Given this list of marker genes Slc39a2, Slc30a1, Slc39a8, Slc39a1, Slc30a8, Slc39a7, Slc39a4, Slc39a3, Slc30a5, Slc39a14, Slc39a6, here is a description of the gene set: Zinc transporters Mouse Gene Set: REACTOME_ZINC_TRANSPORTERS species: Mus musculus